Given this list of marker genes Malsu1, Trmt10c, Coa3, Rcc1l, Taco1, Alkbh1, Mtg2, Fastkd3, Mettl8, Mrps27, Ngrn, Rpusd4, Cdk5rap1, C1qbp, Fastkd2, Trub2, Shmt2, Uqcc2, Nsun4, Mpv17l2, Mtg1 (NCBI Gene Id 212508), Tsfm, Lrpprc, Rpusd3, Rmnd1, Nsun3, here is a description of the gene set: studied in species Mus musculus Mouse Gene Set: GOBP_REGULATION_OF_MITOCHONDRIAL_TRANSLATION Any process that modulates the frequency, rate or extent of the chemical reactions and pathways resulting in the formation of proteins by the translation of mRNA in a mitochondrion.